The following is a description of a gene set: The process of protecting a cell from natural killer cell mediated cytotoxicity. species: Mus musculus Mouse Gene Set: GOBP_PROTECTION_FROM_NATURAL_KILLER_CELL_MEDIATED_CYTOTOXICITY, and this is the list of marker genes: Serpinb9e, Clec2d, Serpinb9g, Serpinb9, Tap2, Serpinb9h, Tap1, H2-M3, Serpinb9c, Serpinb9f, Serpinb9b, Serpinb9d, H2-T23